Given this list of marker genes GALNT13, BPESC1, TMEM30A, NLRX1, SLC7A9, DSG1, MS4A5, TBL3, CREB3L1, SNURF, TSPAN8, IRF4, ICOS, SPACA9, CABP5, ELAPOR1, INVS, ASB12, KIF3B, HTR2B (5-hydroxytryptamine receptor 2B), ADARB2, TYMP, DDX39B, SH3TC1, ZNF214, NCF2, NXPE4, ZNF462, CDC14A, TXNIP, ROBO4, LAMTOR5, GTF3C4, COBL, ARSB, MEGF11, ADAMTS5, LINC00839, POLE2, CELA3A, N6AMT1, ITLN2, NFATC2IP (nuclear factor of activated T cells 2 interacting protein), SOX1, ZNF175, NTRK3, GRB2, WDR75, EIF4EBP1 (NCBI Gene Id 1978), CELSR3, P2RY6, C8orf34, VWF, NOX4, ORC6, APOBEC1, PIMREG, SLC25A28 (NCBI Gene Id 81894), FXYD2, TSHB, REM2, TOX4, PURG, PCNP, HMBS, MCF2L, NOTCH1, SYNGAP1, KMT5C, PGLYRP4, ART3, TAFA5, HPCAL1, ANKRD26, FASTKD1, ZNF365, PRRG3, FOXJ1, STYXL2, SPDEF, DENND3, GIMAP5, TEX14, TMEM40, PER1, ACE2 (NCBI Gene Id 59272), PLPPR4, GLT8D2, USP6, KLHL3, CCS, TERT, TLL2, NRP1, DPF3, BSCL2, MYL2, ICMT, SCAPER, FAM135B, ANO3 (anoctamin 3), PPDPF, SYN1, GABRA2, DDN, H4C3, CNBD2, DHRS3, VAMP5, PRKACB, CRYGA, MRPS31, CPA1, TMCC3, LRRC37A, FAM199X, EMP2, DIS3, INMT (NCBI Gene Id 9171), ERMN, KLHL25, DNAJC10, SPO11, SOHLH2, TCIM, OPHN1, MUCL1, SANBR, GIT2, ETAA1, KCNMB3, TMC5, TMED5 (transmembrane p24 trafficking protein 5), RFX7, DMXL2, PDE5A, ARHGAP45, EPS8L3, ZBTB25, SRPK1, GRIK2, PGS1, SAMHD1, PSCA, SYNPO2L, TOP6BL, CDKN2B, PLA2G12B, PABPC3, POPDC2, PHKG1, FOXF2, MYO15A, OAS3, TBC1D8B, COL20A1, PRDM10, LGMN, TTN, SMPD2, TNNT1, TRAPPC6A, STAR, EEF1G, GRIP2, ID2B, ZNF79, RHOT1, KRT10, AHSG, HMGA1, RBM15, FEZ2, ZNF333, PPAT, BICD1 (BICD cargo adaptor 1), ZNF211, STK25, HOXB13, IFTAP, NUSAP1, GRP, SLC22A2, TDRKH, HOOK1, DDA1, RBM17, TMEM231, OTX2, AJAP1, ENTREP1, AK1, AKAP4, TINCR, MYBPH, RGS14, BTC, OTOF, HAS2, PPFIA2 (NCBI Gene Id 8499), SLC52A1, ADPRHL1, KLK4, SLC16A4, ACTN1, MCPH1, PLCD1, DPM3, TRPA1, EGF, GNGT2, BCAS1, BSN, BMPR1B, EPB41L4A (NCBI Gene Id 64097), MAPRE1, CECR2, ERO1B, PPP1R13B, HRAS, HSPB2, ZCCHC4, BCAP29, PAX2, IL33, SIAH1, LINC01549, MAPK9, CD99L2, CYP39A1, SLC22A8, PRSS3, KCNJ4, HCG4, FAM234B (NCBI Gene Id 57613), FBXL5, TPK1, AQP2, VIL1, STX1B, GSN, HOXB8, WNT10B, RBMS1, METTL16, GCM2 (glial cells missing transcription factor 2), TOX2, GALNT15, KCNV1, S1PR5, AKT1, SFTPD, PERP, EDN2, ALKBH3, TIRAP, TFPI, RAB27A, DYNC2I1, EMSY, SNX8, DNAJC28, GPRC5C, UBE2E1, TBX5, TGM3, CPA6, CD72, CPED1, GPC5, NLRP12, ITIH5, CELA2A, VPS45, C22orf31, TTI1, PBK, ZNF343, RPS2, CYP2A7P1, TMEM200A, FAM83D, XKR4, OR2I1P, ADAMTSL1, ACYP2, CA4, ANKZF1, TXNDC12, NFATC4 (NCBI Gene Id 4776), PRR5L, YWHAE, ZNF777, GPC4, CIRBP, TMA7, HIF3A, TOR2A, CDX1, ZNF408, PCDHB15 (protocadherin beta 15), LRRC8D, PGAP3, ASAP3, DMWD, HTRA2, BEND5, DSG2, MRGBP (NCBI Gene Id 55257), GPR35, MED15, SYT4, FSTL4, WDR46, KCNA4, MYT1L, GTF3C1, BEST3, CSMD3, RGS8, PLXDC2, CAPNS2, ZNF195, ADAMTS10, ADORA1, SGSH, ROBO1, CCHCR1, MAP1A, NAT8, KLK11, ARMCX5, RHO, STRA6, here is a description of the gene set: Genes in the cancer module 48. studied in species Homo sapiens Human Gene Set: MODULE_48